Given this list of marker genes SNORA70F, EXOSC8, RNPC3, SRRM1, TYW1B, TIA1, ZNF326, RBM48 (NCBI Gene Id 84849), SNORA40, SNW1, ZCRB1, PRP4K, TSEN15, SCARNA18, INTS7, USP22, RAMAC (RNA guanine-7 methyltransferase activating subunit), SNHG1, FRA10AC1, RRP1B (ribosomal RNA processing 1B), LUC7L2, ZPR1, TSN, SNORD116-24, RBMS1, RPPH1, SNORD58B, SNORA31B, BRDT, HNRNPLL, TFB1M, YTHDF2, SNORD6, ELAC2, SNORA41B, SRFBP1, RNU6-7, SNORD114-25, SRSF7, CSTF2, SNORD32B, NGDN, MRM2, UTP6, SNRPG, GTDC1, SSU72L6, SNORD115-2, SNORA40C, SNORD116-27, FTSJ1, SNORA73A, SNORD115-24, RNVU1-8, SNORA70D (small nucleolar RNA, H/ACA box 70D), SNORD3H, HNRNPUL1, TRMT1, SLC39A5, FAM98B, SNORD115-15, YBEY, PUM1, SNORD37, CLK3, C9orf78, TUT7, KRR1, RNVU1-2A, SNORD41, BCAS2, SNORD113-4, ZC3H10, SNORD24, TFB2M, MBLAC1, THADA, PTBP2, SNORA77, SNORD15B, RBM25, ATXN7, SNORD38C, NOVA2 (NCBI Gene Id 4859), CSDC2, SNORD88B, SNORD31B, RBM12, SRRT, UTP3, SNORA11D, SUPT20H, USP36, RBMY1F, SNORD90, SNORD115-5, SNORD114-16, TMBIM6, SCARNA23, SNORD114-3, KTI12, FCF1, SNORA58B, PA2G4, THOC5, RSRC1, FBL, TRMT112, RPL7L1, UTP11, CPEB1, SLBP, SNORA25B, SNORA16B, TAF12-DT, SNORD114-27, HSD17B10, SNORD115-41, SCARNA6, CPSF2, FASTKD1, PIH1D1, RPRD1B, CDK11B, RPS7, NSUN6, ENY2, PUS10, ADARB2, SNORA7B, SF3B6, ZRSR2, TSEN54, RBMXL2, CDK9, ALKBH5 (NCBI Gene Id 54890), MBNL3, CWC22, SCARNA21, PPP1R9B, SNORD84, SNORD115-35, RPL27, SNRPN, RBM10, PRORP, NOP10, SNORD114-17, SNORD17, EXOSC2, SCARNA20, SNORA80B, SNORA30, PHF5A, LSM8, RBM44, TRUB1, SLC38A2, SNORD116-15, BICD1, NOP14, IVNS1ABP, FTSJ3, RNF113A, SNORD38B, HMX2, METTL15, NUP155, ELP4, SFSWAP, RPS19, RPS26, SCARNA2, TAF6L, SNORD109A, SGF29, SNORA70I, SNORD58C, CHD7, SNORD115-1, SNORD115-14, METTL3, DALRD3, SNORD28B, PCF11, RRP7BP, SNORD115-11, SNORD63, PRKRIP1, WDR12, DHX9, TBL3, SF3B3, TDRKH, WDR18, DDX52, BUD13, XAB2, SNORD65, SNORD56, RNU4-1, SNORA71B, SNORD115-37, RTCA, OSGEP, SNORA29, SNORA48B, SNORD114-31, AFF2, TSR1, NOL7, SNORA48, SNORA17A (NCBI Gene Id 677804), UPF1, SNORA6 (small nucleolar RNA, H/ACA box 6), SUPT6H, SNORD101, PRX, FBLL1, NUDT16, FUS, PABPN1, POP4, CCNL1, SNORA19, ESRP1, RALY, EXOSC5, TRDMT1, DDX49, SNRPGP15, ANGEL2, ISY1, SNORD61 (small nucleolar RNA, C/D box 61), SNORA70G, RBM28, SRSF4, HNRNPF, RBM15B, DNTTIP2, SMAD1, SNORA41, LSM10, USB1, TCERG1 (NCBI Gene Id 10915), SFPQ, CTNNBL1, CDC5L, SNORA51, RNVU1-19, SF3A2, SNORA26, SON (NCBI Gene Id 84155), TRIT1, REXO1L1P, SNORD38D, RRS1, SNORD2, PNLDC1, SNU13, TRRAP, PRPF8, PIWIL2, TDRD6, CD2BP2, UTP25, SNORD117, SNORD21, GCFC2, RBMY1A1, ELP2, LYAR, AHNAK, SRPK3, ELP3, RPUSD4, KHDC4, MAGOHB, SNORD115-44, RIOK2, RBPMS2, SCAF1, SNORA25, SNORD113-5, SNORD114-22, SCARNA17, PLRG1, QTRT2, MEPCE, SNORA70C, HNRNPA0, SNORD116-30, TARDBP, METTL2B, SNORD113-7, TSSC4, LIN28B (NCBI Gene Id 389421), EIF4A3, NOLC1, CPSF1, SAGE1, SREK1, PCAT18, SNORA50A, TPRKB, SNORD3A, MTERF4, SNRPD2, SNORD116-21, TDRD9, TRMT1L, METTL14, HNRNPA3, SNORA7A (NCBI Gene Id 619563), SNORD19B, RNMT, SNORD5, DUS4L, SNORD35A, DDX5, SNORA56, PPIH, FMR1, CDK13, FARS2, PAN2, SNORD13D, PUSL1, GRSF1, SNORA17B, GEMIN6, BMS1, DHX15, TRMT9B, RPRD2, PRPF40B, SCARNA9, SNORA21, PPIE, SNORA70B, SCARNA5, RNU6-1, RBM20, STH, SNORA70 (small nucleolar RNA, H/ACA box 70), SIRT7, TRIM71, SNORA71E, SMAD3, SSU72L3, ATXN1, BYSL, A1CF, SSU72L5, SNORD108, RAMACL, SNORA24B, EXOSC1, SNORD115-26, SNORA27, RNVU1-17, TRMT61B, SNORA9B, LAS1L, DHX8, SNORA11C, SYMPK, SNORA24, ZNF830 (zinc finger protein 830), AK6, SNORD18C, SNORD70, PARN, SNORA54, SNORD59A, SNORA1B, SNORD70B, PAK1IP1, SNORA57, CRNKL1, METTL25B, FTO, SNRPC, SNORD114-6, UTP18, PWP2, URM1, SNORD8, DDX1, HNRNPA1, NCBP2L, RBM22, CDKAL1, DAZAP1, CPSF7, CMTR2, INTS14, SNHG29, TFIP11 (tuftelin interacting protein 11), PES1, PPIG, CIR1, SNORD114-2, POP1, SNORD114-10, TRMT10B, SNORD22, RNU11, CCNL2 (cyclin L2), METTL16, AGO2, RNU1-4, TGS1, ELP5, RIOK1, NOVA1, KAT2B, SCARNA11, SNORA71C, RPP38, SUV39H1, TRMO (NCBI Gene Id 51531), INTS6L, SCNM1, RNVU1-14, MAEL, SNORD114-28, INTS3, PLD6, SNORD23, SNORD64, SCARNA16, DUS2, H2AB1, DUS1L, CDK12, TRMT13, NOL10 (NCBI Gene Id 80085), SNORD115-13 (small nucleolar RNA, C/D box 115-13), ESF1, SNRNP200 (NCBI Gene Id 692221), SNORA59B, PRPF18, NPM1, PPIL2, ELOVL2-AS1, GEMIN5 (NCBI Gene Id 25929), CDKN2A, GPATCH1, SNORD116-1, REXO1, MIR664A, DHX40, PUS7, SNORD14D, WDR33, U2AF2, SNORD126, SNORA71A, ADAR, SNORA68, NUFIP1, SNORD45A, SNORD62A, TP53, SNORD56B, SRSF9, ADAD2, SNORD116-2, NUP98, SNORA5A, SNORD115-34, RPP25, SNORA22, SNORD12B, SNORA3C, DDX39B, PRMT5, SNORA63C, RPL35, TRPT1, SUPT7L, PDCD11, YJU2B, WDR46, DHX38, PIWIL1, STAT3, SNORA38B, SNORA36B, SNORD88A, SNORD91B, SNORD113-6, ERI1, SCARNA10, SNORA53, DBR1, SNORA8, SF1, PRPF6, ZMAT2, INTS9, RPS14, DHX36, LARP6, SNORD116-16, SNORD114-19, ARL6IP4, NSA2 (NSA2 ribosome biogenesis factor), SNORA36A, GEMIN7, REXO4, SNORD97, DDX41, BMP4, SUGP2, RBM17, TSEN34, SNORA80A, AAR2, CELF3, RPL5, RBMY1D, RBFOX1, CHERP, SNORD114-15, SNORA55, ECD, RPUSD3, FAM50A, RBFA, METTL18, SNORA79, CPSF6, SNORA2C, SNORD88C, RPP25L, WBP11, SNORA75, ISG20, SNORD45B, NOL9, EXOSC9, CSTF1, FASTKD2, EMG1, SNORD115-38, TARBP2, RBM34, SNORD116-19, SNORA30B, ERN2, SNORD114-26, SNORA49, DHX16, SNORD14B, MYG1, SNORD34, SCARNA7, SNORA50C, LGALS3, PAPOLB, PPIL3 (peptidylprolyl isomerase like 3), SNORD18A, HNRNPD, SNORD3G, NONO, ADAT1, LSM5, SUGP1, INTS12, AHNAK2, FAM98A, SNORA4, RPS21, RBM5 (RNA binding motif protein 5), UTP14C, PCIF1, HNRNPC, WDR6, RBM24, TAF12, SNORD116-23, MFAP1, CIRBP, SNRNP48, SNORA74A, YBX1, ZNF473 (NCBI Gene Id 92653), ARVCF, SNRPB2, RBM42, TADA2B, DCAF13, SNORD36B, SNORA63E, POP5 (POP5 homolog, ribonuclease P/MRP subunit), CDK11A, AEN, NSRP1, TRMT61A, TRMT11, LARP7, SNORD60, METTL4, RPL7, PIWIL4, TAF5L, GPKOW, TYW5, SNORA28, SNORA36C, STRAP, ZC3H7B, THUMPD2, RPS16, NCBP2, ELP6 (NCBI Gene Id 54859), SNORD13, DICER1, SNORD14A (NCBI Gene Id 26822), SNORA11B, PPWD1, SNORD115-40, SNORD115-20, TAF15, PRKRA, CDC40, RNASEL, SNORD116-6, SNRPE, PUS1, BCDIN3D, INTS1, SRSF12, MPHOSPH10, PDE12, RBMX2, RNPS1, SNORD43, BUD31, LSM1, SNORD95, THOC3 (THO complex subunit 3), AARS1, U2SURP, TSR3, RBFOX3, SNORA65, TRMT2A, SNRPB, SNORD114-4, SNRPA1, MBNL1, RBM47, METTL2A, WDR43, CLP1, RNU5E-1, SYF2, SNORD28, SCARNA14, AGO1, SNORA5C (NCBI Gene Id 677796), CELF2, CELF1, SNORD49B, SF3A1, SNORD112, RNU2-1, SNORD18B, DDX47, RUNDC3A-AS1, PAXBP1, TBRG4, SNORD83B, SMNDC1, WBP4, SNORA79B, SNORA3B, SEPSECS, SNORD138, ZNHIT3, GON7, SNORD11B, NVL, SNORD26, SNHG7, JMJD6, CDK5RAP1, CWF19L2, SNORD123, SNORD114-11, ZCCHC4, SNORA70J, FIP1L1, APOBEC2 (apolipoprotein B mRNA editing enzyme catalytic subunit 2), MIR1248, SNORD53B, SNORA72, CMTR1, SNORD116-25, UPF3A, DGCR8, AGO3 (argonaute RISC catalytic component 3), SNRNP40, CWC15, EIF6, SNORD116-26, RPS6, DDX21, SNORD116-4, ALKBH8, TRMT2B, NOP58, SMU1, RPS24, SETX, PAPOLA, MPHOSPH6, SNORD81, SNORD3E, ILDR1, SCARNA4, SRPK1, SNORD115-10, HENMT1, ARB2A, FASTKD3, SNORD52, CWC25, BARD1, TXNL4B, SNORD58A, SNORD115-45, CENATAC, PRPF39, SNORD93, KHDRBS1, SNORD115-17, HNRNPA2B1, INTS10, RPP14, SNORD27, ZC3H14 (NCBI Gene Id 79882), SNORD114-23, MOCS3, SNORA80E, RNU6-9, SREK1IP1, SNORD9, WDR77, SNORD69, TERT, SNORD116-13, SNORD114-18, ZRSR2P1, SNORD115-30, SART3, POLR2A, TRMT10A, LIN28A, HNRNPK, NOP56, TRNT1, INTS8, TDRD1, SNORA20B, YTHDC1, SNORD3D, ESS2, ZFC3H1, TRMT10C, OSGEPL1, ANKRD16, PWP1, TRMT5, SRRM4, RCL1, SNORD116-12, SRSF5, SSU72L2, IMP4, ALKBH1, SNORD114-13, UPF3B (NCBI Gene Id 65109), SNHG12, PRMT9, SNORD115-33, RBM15, RRP7A, PRPF38A, WDR55, CPSF4 (cleavage and polyadenylation specific factor 4), DHX35, KHSRP, PABPC4, EXOSC7, RBM4B, SCAF11, RBM3, SNORD36A, SARS1, IWS1, SNORD116-14, LSM4, SNORD114-5, SNORD113-3, ALYREF, SNRPD1, HDAC7, YJU2, SNORD13E, SNORD98, DIS3L, SNORA15, CRIPT, WDR4, RP9 (RP9 pre-mRNA splicing factor), SNORD114-9, RTRAF, CLK2, SNORA47, TADA1, SNORA74C-1, RPF1, FASTK, UBL5 (NCBI Gene Id 59286), SPOUT1, DDX17, PRPF19, SF3B4, RBPMS, SNORD115-28, WEE2-AS1, SNORD115-8, NSUN7, SNORA68B, SNORD116-5, RPP30, ELAC1, GEMIN4, SLX9, SRSF3, TUT1, RBM12B, U2AF1L4, RBM39, THG1L, PIN4, ADAD1, RBM41, THOC1, TMTC1, C2orf49, SNORD99, SNORD115-32, FBXO24, HNRNPH2, HOXB-AS3, SNORD71, SNORA44, NOP2, PIK3R1, SNORA2A, CLNS1A, SNORD20, DIMT1, RNVU1-15, SUPV3L1, NRDE2, RPUSD1, USP4, RPP40, CNOT6L, SNORD94, PRPF3, SNORD114-14, PIH1D2, PELP1, MYOD1, METTL8, SRSF10, SNORD115-27, KRI1, PPP4R2, SF3B2, RIOK3, DPH3, PUS7L, SCARNA12, RBMY1E, SNORA70H, HSPA8 (heat shock protein family A (Hsp70) member 8), SNORD57, APOBEC1, UMOD, SNORA20, HNRNPH3, HNRNPM, RPL7A (NCBI Gene Id 6130), IK, ZBTB7A, M1AP, SNORA32, GAR1, SNORA31, NSUN4, ZNF638, SNORD66, SNORD116-18, AICDA, MIR664B, SNORD115-22, SNORD116-20, CSTF3, SLTM, SNORD63B, RNVU1-6, RNU4-2, SNORA60, RPL11, CHD8, SNORA70E, CCNB1, SNORA80C, CWF19L1, SNORD50B, THOC7, HNRNPL, UTP14A, SNORA63B, WTAP, LSM7, SNORD77B (small nucleolar RNA, C/D box 77B), RIPK1, GTPBP3 (GTP binding protein 3, mitochondrial, NCBI Gene Id 84705), PTBP1, SNORA50B, LSM2, DKC1 (dyskerin pseudouridine synthase 1), FDXACB1, TUT4, SNORD115-31, SRRM2, NUDT21, SNORD32A, LSM3, SNORA3A, SNORD87, RNU4ATAC (NCBI Gene Id 57788), NOL11, SNORD114-7, POP7, ZBTB8OS, WDR3, SNRNP25, SCARNA3, ZC3H3, HEATR1, SNORD83A, DDX39A, PTCD2, HABP4, SNORD115-25, UTP20, COIL, SNORA66, SNORA40B, PCBP4, SNORD4B, SNORD1B, SNORD115-42, RBMX, SNORA78, SNORD36C, CLASRP, PAF1, KHDRBS2, CELF5, DDX51, NSUN3, RBM7, SNORD116-8, ATXN7L3, PPP1R8, KAT2A, MIR3651, RPP21, ESRP2, SNORA67, THUMPD3, ZC3H13, RBM38, NHP2, RNVU1-3, SNORD107, RRP9, TRA2A, SNORA80D, SNORD111B, PUS3, MTREX, RPL26, FASTKD5, INTS15, KIN, TDRD12, SSU72, RTCB, RRAGC, MTPAP, SART1, METTL5, TSEN2, SNORD111, TENT2, ZC3H7A, AHCYL1, DDX23 (NCBI Gene Id 9416), THUMPD1, CTU1, SNORD53, DNAJC17, PAPOLG, METTL6 (methyltransferase 6, tRNA N3-cytidine), NPM3, ERN1, SMN2, SNORA71D, NOB1, RPS27, SNORA10B, SCARNA22, SNORD67, SNORD68, INTS11, SCARNA21B (NCBI Gene Id 107397391), SNORA73B, GEMIN8, SNORD104, LSM6 (NCBI Gene Id 730962), DDX20, SNORD113-9, PUM2, INTS4, EXOSC10, SNORA22B (NCBI Gene Id 109616964), HSPA1A, RBMS2, SNORA69, SSU72L1, DDX27, RPUSD2, SNORD116-3, SNORA15B-1, SNORD105B, SNORD16, SRSF8, SNORD102, SMN1, UTP23, SNORD74B, THRAP3, SCARNA13, SNORD115-4, SCARNA8, SNORA33, MAK16, SNORD115-48, NOC4L, BUD23, TYW3, SNORD65B, ABT1, RNU5B-1, DDX10, RPS28, REXO5, SNORA1, ADARB1, SNORD14C, SNORD65C, TAF9, SNORA14B, IMP3, SNORD116-22, EXD1, LAGE3, DTWD1, RBMY1B, SF3B5, SNORA84, CLK1, RBMXL3, NBDY, SNORD100, GEMIN2, SNORA77B, TSNAX, AGO4, SNORD19, MRM3, SNORD125, RPS15, SDE2, SCARNA18B, REST, SNORA13, SNORD49A, NOP9, AKT1 (AKT serine/threonine kinase 1), DDX46, WDR83, UTP4, PSIP1, PRPF31, PAN3, SNORD121A, TSR2, SNORD30, CACTIN (cactin, spliceosome C complex subunit), NOL3, GTPBP4, TOE1, SNORA38, TYW1, ELAVL4, PRPF4, YRDC, RBM11, SNORD127, KHDRBS3, SNORD86, SRSF2, SNORD7, RRP1, QKI, SNORD115-46, NAF1, SNORA46, XRN2, SNORD116-10, RNVU1-7, RNU105C, RRP36 (ribosomal RNA processing 36), NCBP1, SNORD115-6, SSU72L4, NCL, DDX56, DYRK1A, SCARNA15, RBFOX2, DUS3L, VIRMA, SNORD115-7, TENT4A, ZCCHC8, SNIP1, DROSHA, TTF2, PUF60, SNORD73A, SNORD115-23, SNORA75B (small nucleolar RNA, H/ACA box 75B), RBM4, LUC7L3, GPAT2, QNG1, TXNL4A, TRMT44, SYNCRIP, THOC2, SRSF1, SNORA18 (NCBI Gene Id 677805), RPS13, SNORA9, FKBP6, TENT4B, SNORD33, PRDX6, URB1, TRA2B, SNORA74B, ZNHIT6, SNORD3C, MIR6516, PRPF38B, SNRNP27, ARMC7, RPRD1A, SNRPF, METTL1, HNRNPUL2, CELF6, SNORD115-21, NAT10, PTCD1 (pentatricopeptide repeat domain 1), HNRNPDL, NCBP3, CDC73, KAT8, RNVU1-4, SNORD1A, ILF3, BOP1, IL6, SNORA14A, SNORD42B, GTSF1 (NCBI Gene Id 121355), CCAR2, SNORD54, MOV10L1, SNORD48, EXOSC3, RBM8A, DDX18, TRMU, THOC6, RPL14, CBLL1, ZMAT5 (zinc finger matrin-type 5), NSUN2, PTBP3 (polypyrimidine tract binding protein 3), MRM1, WDR74, APOBEC4, SF3B1, SF3A3 (splicing factor 3a subunit 3), USP49, GTF2H5, DTWD2, TP53RK, DHX37, SAP18, ADAT3, EBNA1BP2, NOL8, HTATSF1, SAGE2P, SNORD116-29, TEX15, USP39, SNORA37, INTS6, SNRPD3, SNORD114-21, TARBP1, RBBP6, SNORD105, MTFMT, SNORD114-1, SNORD15A, PNPT1, ZRANB2, C1QBP, RPF2, NOP53, DUSP11 (NCBI Gene Id 8446), SNORD114-29, METTL15P1, QTRT1, SNORA63, DEDD2, SNORA10, SNORD82, SNORA2B, CASC3, LINC01151, SNORA50D, SNORA11, CLK4, ACIN1, TAF10, SNORD91A, RBMXL1, SNORD10, PIWIL3, ARGLU1, RNVU1-1 (RNA, variant U1 small nuclear 1), SRPK2, SNORD45C, RNU6ATAC, INTS13, RBM23, TGFB1, SNORD12, ILDR2, SRSF6, MRPL44, MTO1, SNRNP35, SNORD116-11, PRKDC, SNORD113-8, AKAP17A, SNORA61, RPS8, PRMT1, SNORD114-30, SSB, SNORD124, WT1, SUPT3H, MAGOH, SNORD92, SNORA12, SNORD115-3, AKAP8L, SNORD1C, SNORA5B, SNORD115-9 (NCBI Gene Id 100033446), TMT1A, UTP15, U2AF1, SAFB, TRMT12, ADAT2, RBM6, PWAR5, RRP15, HNRNPR, RPS25, TRUB2, SNORD121B, ZFP36L1, WDR75, SNORD114-24, PPARGC1A, SNORD46, RNGTT, BRIX1, SNORD11, RSRP1, SNORD114-20, SNORD4A, RBMY1J, SNORA64, ZMPSTE24, EFTUD2, SNORD3B-1, SNORA16A, CELF4, SNORD3J, SNORA58, PRKACA, EXOSC4, INTS2, MRTO4, RPS17, SNORD35B, ELP1, LCMT2, HNRNPA1L3, PQBP1, SNORD38A, PRPF40A, GPATCH8, SAFB2, CWC27, AQR, HNRNPU, SNHG10, SNORA11F, RNU5F-1, DDX42, SNORA11G, RPL35A, SNORA35B, HSF1, DIS3, LUC7L, SNORD89, SNRPA, SLU7, TDRD7, CSTF2T, TRMT6, SMAD2, SNORD73B, H2AB3 (NCBI Gene Id 83740), LSM11, LEO1 (NCBI Gene Id 123169), RRP8, SNORD12C, SNRNP70, ISG20L2, DDX4, PNN, PPAN, CPSF3, NSUN5P1, DCPS, SNORA22C, B3GNTL1, SNORA62, PRMT7, RNF113B, PPIL1, PDCD7, ERCC2, SNORA52, PABPC1, EXOSC6, SNORD110, DDX54, HNRNPH1, SCARNA1, H2AB2, CTU2, NSUN5, KARS1, SNORD115-16, RNU5D-1, SNORA35, RNU5A-1, NOL6, MBNL2 (NCBI Gene Id 55479), SNORD51, HNRNPA1L2, SNORD72, INTS5, SNORD55, WDR36, SBDS, RNU105B, NSUN5P2, SNORD115-39, SRSF11, SNORD114-12, C1D, FRG1, SNORA74C-2, RBM14 (RNA binding motif protein 14), TADA3, here is a description of the gene set: species: Homo sapiens Human Gene Set: GOBP_RNA_PROCESSING Any process involved in the conversion of one or more primary RNA transcripts into one or more mature RNA molecules.